Given this list of marker genes Arhgef10l, Rasgrf2, Prkci, Smpd2, Mib2, Tab3, Arhgef19, Ube2d2a, Prex1, Nfkb1, Trio, Net1, Plekhg5, Ywhae, Psenen, Spata2, Traf1, Rela, Bad, Arhgef2, Plekhg2, Rhoa, Sppl2a, Traf2, Otud1, Tab1, Ngfr, Ubb, Vav1, Cflar, Birc3, Itsn1, Arhgef7, Ngef, Casp2, Arhgef10, Usp2 (NCBI Gene Id 53811), Vav3, Smpd3, Ikbke, Akap13, Arhgef16, Ripk2, Fasl (NCBI Gene Id 14103), Clip3 (NCBI Gene Id 76686), Arhgef3, Arhgef17, Chuk, Bex3, Stub1, Vav2, Tnfrsf1a, Psen1, Mapk8, Usp4, Mapkapk2, Tnf, Arhgef33, Birc2, Rps27a, Usp21, Tab2, Irak1, Tradd, Itgb3bp, Rack1, Xiap, Fgd2, Map3k7, Arhgef25, Arhgef15, Arhgef12, Adam17, Otud7b, Rbck1, Arhgef1, Obscn, Bcl2l11, Tax1bp1, Nfkbia, Ube2l3, Tbk1, Arhgef37, Arhgef5, Ect2, Ube2d3, Ikbkg, Sos1, Cyld, Tnfsf10, Uba52rt, Tnfrsf10b, Aph1b, Fadd, Traf6, Ulk1, Optn, Ngf, Arhgef18, Fgd4, Rtn4, Arhgef26, Ubc, Tnfaip3, Sos2, Ube2d1, Sqstm1, Myd88, Mag, Bag4, Tiam2, Nsmaf, Abr, Uba52, Ripk1, Fgd1, Rac1, Fas, Arhgef39, Kalrn, Rnf31, Mcf2l, Fgd3, Arhgdia, Ikbkb, Sppl2b, Lingo1, Mcf2, Arhgef38, Arhgef9, Ncstn, Gna13, Omg, Aph1a, Arhgef6, Arhgef11, Casp3, Casp8, Madd, here is a description of the gene set: Mouse Gene Set: REACTOME_DEATH_RECEPTOR_SIGNALING studied in species Mus musculus Death Receptor Signaling